The following is a description of a gene set: studied in species Homo sapiens Urea cycle metabolism. Human Gene Set: MODULE_440, and this is the list of marker genes: OTC, BBOX1, ACY1, TTR, CKM, CPS1, ASS1, PYCR1, GLUD1, ODC1, CKMT1B, ASL, GATM, ARG1, OAT, DIO1 (NCBI Gene Id 1733), GAMT, CKB, ARG2